The following is a description of a gene set: Marker genes curated from the annotated cluster as represented in the Descartes Human Gene Expression During Development database. from publication Cao J, O'Day DR, Pliner HA, Kingsley PD, Deng M, Daza RM, Zager MA, Aldinger KA, Blecher-Gonen R, Zhang F, Spielmann M, Palis J, Doherty D, Steemers FJ, Glass IA, Trapnell C, Shendure J (PMID 33184181) studied in species Homo sapiens Human Gene Set: DESCARTES_FETAL_LIVER_MEGAKARYOCYTES The gene expression program underlying the specification of human cell types is of fundamental interest. The study authors generated human cell atlases of gene expression and chromatin accessibility in fetal tissues. For gene expression, the study authors applied three-level combinatorial indexing to >110 samples representing 15 organs, ultimately profiling ~4 million single cells. The study authors leveraged the literature and other atlases to identify and annotate hundreds of cell types and subtypes, both within and across tissues. Our analyses focused on organ-specific specializations of broadly distributed cell types (such as blood, endothelial, and epithelial), sites of fetal erythropoiesis (which notably included the adrenal gland), and integration with mouse developmental atlases (such as conserved specification of blood cells). These data represent a rich resource for the exploration of in vivo human gene expression in diverse tissues and cell types., and this is the list of marker genes: DOK6, PLEK, TRPC6, TREML1, PDE5A, NLK, RNU6-299P, LINC02284, PROSER2, CXCL2, CD226, EFCAB13-DT, SLC9A1, CXCL3, MYCBPAP, MAP1A, MMRN1, ATP13A4, ANKRD18DP (ankyrin repeat domain 18D, pseudogene), NEXN-AS1, RSPH1, GP1BA, LGALSL, MED12L, MPIG6B, LINC02770, CDC14B, LINC00534, STUM, THBS1, SLC18A2-AS1, ZYX, LINC02715, RUFY1, F2RL3 (NCBI Gene Id 9002), SLC24A3, ITGA6, ITGA2B, INHBA-AS1, SEC14L5 (SEC14 like lipid binding 5), ACTN1-DT, LINC01565, ANO2, GP5, AQP10, ITGB3, MYH9-DT (NCBI Gene Id 105377199), ENSG00000229727, TGFB1, ACRBP, LINC01923, RGS18, EFHC2, DNAAF3-AS1, LIMS1, MYO3B, ALOX12, HBD, FAM157C, PPBP, DGKI, SIAE, PIRAT1, FLNA, GP6, LEFTY1, CNST, PGAM1P8, HPSE, GRM3, LINC00989, LCN2, TUBB1, RAB3C, CLEC2L, PADI4, DNM3, PF4V1, RAB27B, RAP1B, FHOD1, SRC, ADCY6 (NCBI Gene Id 23320), GNB5 (NCBI Gene Id 82962), EGF, LY6G6F-LY6G6D, LINC02455, LTBP1, NRGN, ENSG00000233968, ARHGAP18, LINC00504, SLC35D3, KIAA0513, FCER1A, SELP, SYTL4, TMEM91, ARMC3, ENSG00000258803, IRAG1, ELOVL7, SPX, MARCHF4, COL24A1, MYOM1, CMTM2, ENSG00000250348, PCP2, TMEM40, LY6G6F, LINC01992, CATSPER1, CASS4, ACTN1, L3MBTL2-AS1, SLC37A1 (NCBI Gene Id 54020), DGKG, MYEOV, HTR2A, ENSG00000245008, CMTM5, LGALS12, CD40LG, SETP11, LINC02267, LRP12, PLXNB3, LAT, NBEAL2, GRM3-AS1, TUBA4A, FBXO40, MDM1, NEXN, RNY1P11 (NCBI Gene Id 106481710), LIPH, LOXHD1, VEPH1, PF4, MPP7, GP9, LINC03044, PRKAR2B, C3orf52, NPM1P27, TNNI3, GPR87, SMIM12, PTCRA, F13A1, LY6G6E, PDGFA-DT (NCBI Gene Id 441307), PRSS27, TUBA8, FERMT3, CDH10 (cadherin 10), GLYATL1P1 (NCBI Gene Id 100129032), TLN1, STX1A, XYLT2, SEPTIN5